The following is a description of a gene set: Astrocytoma is a neoplasm of the central nervous system derived from astrocytes. Astrocytes are a type of glial cell, and thus astrocytoma is a subtype of glioma. Human Gene Set: HP_ASTROCYTOMA species: Homo sapiens Astrocytoma, and this is the list of marker genes: CCM2, PIK3CA, TSC2, CDKN2A, IFNG, IDH2, MDM2, KRIT1, TSC1, NSD1, MSH6, APC, NF1, TP53, PDCD10, ERBB2, PMS2, IDH1, MLH1, CHEK2, MSH3, BRCA2, APC2, FGFR1, NF2